The following is a description of a gene set: An abnormal gait pattern characterized by the failure of the heel to contact the floor at the onset of stance during gait. Human Gene Set: HP_TIP_TOE_GAIT species: Homo sapiens Tip-toe gait, and this is the list of marker genes: SLC39A14 (solute carrier family 39 member 14), PNPLA8, REEP2, FBN1, SYNE1, CHAT, COL12A1, LMX1B, SPTBN1, AIFM1, EMD, KMT2B, RTN2 (reticulon 2), VAMP1, LRSAM1, HARS1, ERLIN1, COL13A1, MYPN, SBF2, TNNT1, KCNA1, BAG3, SNAP25, SGCA, SLC5A7, DDHD2, NT5C2, SPG11, ALDH18A1 (NCBI Gene Id 9193), TLK2, MYO9A, SYT2, MT-TE, KY, TPM3, H4C5, FHL1, ADSS1, VCP, ARSA, TAF4, DYSF, B4GALNT1, PI4KA, KIDINS220, PEX16, TMEM43, BICD2, FKRP, PSAP, DMD, PANK2 (NCBI Gene Id 80025), AGRN, DYNC1H1, POMT1 (protein O-mannosyltransferase 1), IQSEC2, HADHA, MYH7, CRPPA, SLC18A3, CYP2U1, LMNA, FLII, COASY, SMG8, FUS, INPP5K, GFM2, SYNE2, GNPTAB, GNB2, GJB1, YY1, COL6A1, DEAF1, TPM2, MORC2, PLAAT3, ATL1 (NCBI Gene Id 6681), SLC25A1 (solute carrier family 25 member 1), AASS, HADHB, AP5Z1, SPTLC1, SGCG, FKTN, RAI1, KIF1C, ALS2, SIGMAR1, CAPN3